Given this list of marker genes TEX15, THG1L (tRNA-histidine guanylyltransferase 1 like, NCBI Gene Id 54974), HMGB2, SPRING1, RAB11FIP1, UCKL1, PITPNA, GNAZ, COL5A1, VSTM4, SCD5, IRS2, GSC, TCAF2P1, HK2, SEPTIN5, CD320, TNFRSF10D, RAP2B, MYB, RALB, CENPV, IMPDH1, TARBP2, PTPN5, AKT1S1, IQSEC1 (NCBI Gene Id 9922), CCT8, NOL12, ICMT, UBTF, BAALC, AASS, AGO2, FAM135A, NT5DC2, TMEM268, HPS3, RYK, CLCN2, CHD3, ANKDD1A, RDX, ITPKA, MRM1 (mitochondrial rRNA methyltransferase 1), ZIC2, KMO, TP53I11, TBX5, CDK2AP1, FRMD4A, TUBB4A, BAG4, COL6A2, MED15, CNTNAP2, RGS19, SLC1A3, PODXL, PCSK6, PEG10, ADGRA2, NKX2-2, SH3PXD2A, PKIA, EIF4A3, FZD5, TNFSF13B, CTXN1, ADCYAP1R1, C12orf75, PPP1R1A, GRPEL1, ATP13A3, ZNF584, FARP1, SUCLG1, NOG, WWC3, HYAL2, BCOR, TRAM2, DNER, SLCO4A1, AEN, MTPN (NCBI Gene Id 94351), DNMT1, RBPJ, COL4A1, PTP4A1, IPO11, TMEM41A, POLR1A (NCBI Gene Id 90784), ACIN1, ARID1B, LPAR3, KIAA0408, PTS, GLB1L2, BOC, FKBP4P7, TEAD1, MTMR1, DLX5, TPM1, TYSND1, FN1, XPR1, PACC1, SMAD6, THEMIS2, SLC16A1, CERCAM, MAPK3, CORO1A, ADGRB2, TAOK2 (NCBI Gene Id 9344), PRMT5, ACBD3, PTP4A2, NCOA5, DLG4, CPXM1, SAR1B, STX2, POLR2C, CNOT6, PITHD1, NDN, TRIB2, RBM24, HR, NR4A1, ALDH9A1, ADARB1, SLC29A1, NFYA, GSN, NEIL2, MTHFS, PPIF (peptidylprolyl isomerase F), ADA, TIPARP, CNIH4, MMP2, ABCA2, PXYLP1, SPTBN2, APLP1, BGN, MBOAT7, MED13L, GFRA1, KCNAB3, SLC39A14, ASIC1, AKAP8, POLR3K, TENT4A, NPAS2, RALGDS, LARP6, NCOR2, ADA2, SLC2A1, CYP27B1, SOCS4, PAWR, TIMP2, BET1, ANKH, TOP1MT, POLR3E, RGS4, GTF3A, INPP5A, P2RX5, ANKRD29, ZFAND6, MRPS6, GRK2, RP2, NMNAT3, PJA2, MFSD2A, BHLHE22, PEA15, FZD1, CYP27C1, MAP3K12, BARX1, STEAP3, KAT5, TLE5, BRD3OS, EDIL3, EYA2, UBE2Q2, RNF145, SRD5A3, WDR90, IGSF9, MCAM, CACNA1G, SLC29A4, OBSCN, TDO2, CLDND1, URGCP, ZMYND19, ELN, APEH, LANCL2, B4GALT5, NXPH4, TNFAIP6 (NCBI Gene Id 7130), S100A10, PIAS2, TLCD3A, OSGIN2, CLPP, STK35, FAM110A, CDON, RCL1, PRRC2B, TMEM54 (NCBI Gene Id 113452), B4GALNT3, DLGAP4, FAM83D, BMP7, UGP2, RBP1, TCF3, GLI3, LOXL2, SLC17A7, SRF, LUZP1, APCDD1, EMC9, DOCK6, CLIC4, ISOC2, RPS19BP1, PDE9A, ADI1, USP31, LAMTOR1, ASH1L, PSMC3IP, EFHD1, IDH3A, TCFL5, ADCY9, SPR, NELL2, MGAT1, SLC25A10 (solute carrier family 25 member 10), TUBB2B, RUSC1, FHL3, TIMP3, YES1, PIGW, MTMR6, CEACAM21, RABL6, KLF13, WNT5A, SEC63, SBNO1, ATP11C, FTSJ1, CYRIA, SPTLC1, NOTCH3 (NCBI Gene Id 791), CCDC3, KPNA1, VWCE, PRDM8, KCTD15, HIP1 (NCBI Gene Id 3092), AGAP3, COL13A1 (collagen type XIII alpha 1 chain), ZFYVE9, QKI, ALDH1A3, PMAIP1, MGARP, MRPS35, ZNF92, ZYX, SREBF1, IL10RB, INPP4B, CDH24, EMP2, DAP3, PLTP, ANAPC15, MPP1, CACNB3, LSM7 (LSM7 homolog, U6 small nuclear RNA and mRNA degradation associated), LAMTOR3, TRIM3 (NCBI Gene Id 10612), SNORD62A, SPRED2, CARS2, FBN3, HMGA1, PANK3, OIP5, MTFP1, ZDHHC20, LPCAT1, HUNK, GLO1, TMEM51, XYLT2, IL27RA, CYB5B, ARG2, SF3B4, BCL9, GNL2, NDUFA5, KIF20A, OSBPL11, ATG9A, C11orf24, DCXR, SHLD2, RTF1, UNG, PWWP2B, ZNF146, RAB26, ULK1, MACF1, CXCL14, EIF2B4 (eukaryotic translation initiation factor 2B subunit delta), PAPPA, B3GAT1, TUB, DAB2IP (DAB2 interacting protein), CKB (NCBI Gene Id 96634), E2F3, WASF1, TPPP3, PDE4A, POGLUT3, GALNT17, ACYP1, SLC6A6, CNIH2, ITGB5, FXYD5, TRIL, NUP43, H4C13, ARL13B, DHX40P1, LMNB2, CDK14, DNAJC7, HIPK3, ZBED4, HRAS, PNP, ROS1, LRP8, EFNB1, OLFM1, INS-IGF2, RND2 (Rho family GTPase 2), LRATD2, GDF11, C15orf39, NUDT15, DIDO1, DDX6, DCHS1, RBM38, CCDC180, RUVBL2, EIF4E3, HSP90AA2P, KMT2A, EIF1AXP1, CALML4, SAMD1, UCK1, TMEM163, RBM15B, CTSC (NCBI Gene Id 50958), SH3BP5, NCLN, SLC37A4, UBL4A, LOXL1, TUBB6, SGTA, GALNT14, ARHGAP17, EIF4E2, TRIAP1, NID1, CABLES1, MTURN, BLTP2, COL4A2, TMEFF1, SS18L1, TPM2, SCD (NCBI Gene Id 6319), BASP1, GPN1, CDKN3, PLOD3, DUSP6, MYBBP1A, F2R, TRPV4, ATP1B1, LRRC17, ATE1, TCIRG1, CRMP1, SDC1, KIF11, PLPP2, SCAMP1, FASN, POLD3 (NCBI Gene Id 10714), FSD1, CRYM, CITED2, KCTD12, RHOBTB2, TRMT6, AGPAT5, PRC1, RNF122, INPPL1, IL6ST, USP39, TBC1D16, GDI2, CACHD1 (NCBI Gene Id 57685), PLCB3, DHX9, VSIG10, CRABP1, IL11RA, NUP93, RAB15, DKK3 (NCBI Gene Id 51583), DCBLD2, WDFY1, BLOC1S5, GPR162, GRP, HOXC9, LGR5, FGF13, GAL, NEO1, PLOD1, MPRIP, KDM1A, DUSP26, CHEK1, PGAM5, SELENOI, ATF2, DKK2, SPAG5, ADAMTS1 (NCBI Gene Id 9510), TUBB2A, RASAL2, MFAP4, INA, ANGPTL2, RIT1, GPRC5B, LOXHD1, OLFML3, IGDCC4, SARM1, CS (NCBI Gene Id 94822), ZNF367, SCARB1, SLC41A1, THY1, TSPAN7, PLPPR2, PDE1B, TMEM184B, PDP1, CDH23, HNRNPUL1, PLXNA3, TLN1 (talin 1), KLF11, SP3P (NCBI Gene Id 160824), SEC24B, NUDCD1, CARM1, CMTM7, SNORD41, PTGFRN, DUS3L, HOXC11, RECQL4, IFRD2, PDGFA, H4C2, PCGF1, MAPK1IP1L, NR2F2, MAP3K21 (mitogen-activated protein kinase kinase kinase 21), TNRC6A, SS18, PRKAR2B, SLC7A3, ATF1, SNX27, DSP, TOMM34, CPNE7, EML3, HNRNPD, IQGAP1, PCBP4, FAM174C, FGFR4, TMEM50B, YWHAH, PRPS2, ILF3, HYOU1, CAMKV, RBPMS2, FAAP20, UXS1, NOTCH1, PYGB, REEP4, SHANK1, RASL10B, ACACA, CERS1, LSM14A, UGCG, COL6A1, COL16A1, NPTN (NCBI Gene Id 27020), C1QL1 (NCBI Gene Id 10882), ECM1, PDGFC, MSX2, HDAC7, here is a description of the gene set: species: Homo sapiens Deregulation of the polycomb group gene BMI-1 is implicated in the pathogenesis of many human cancers. In this study, we have investigated if the Ewing sarcoma family of tumors (ESFT) expresses BMI-1 and whether it functions as an oncogene in this highly aggressive group of bone and soft tissue tumors. Our data show that BMI-1 is highly expressed by ESFT cells and that, although it does not significantly affect proliferation or survival, BMI-1 actively promotes anchorage-independent growth in vitro and tumorigenicity in vivo. Moreover, we find that BMI-1 promotes the tumorigenicity of both p16 wild-type and p16-null cell lines, demonstrating that the mechanism of BMI-1 oncogenic function in ESFT is, at least in part, independent of CDKN2A repression. Expression profiling studies of ESFT cells following BMI-1 knockdown reveal that BMI-1 regulates the expression of hundreds of downstream target genes including, in particular, genes involved in both differentiation and development as well as cell-cell and cell-matrix adhesion. Gain and loss of function assays confirm that BMI-1 represses the expression of the adhesion-associated basement membrane protein nidogen 1. In addition, although BMI-1 promotes ESFT adhesion, nidogen 1 inhibits cellular adhesion in vitro. Together, these data support a pivotal role for BMI-1 ESFT pathogenesis and suggest that its oncogenic function in these tumors is in part mediated through modulation of adhesion pathways. Human Gene Set: DOUGLAS_BMI1_TARGETS_UP from publication Douglas D, Hsu JH, Hung L, Cooper A, Abdueva D, van Doorninck J, Peng G, Shimada H, Triche TJ, Lawlor ER (PMID 18701473) Genes up-regulated in A4573 cells (Ewing's sarcoma, ESFT) after knockdown of BMI1 by RNAi.